Given this list of marker genes Alkbh5 (alkB homolog 5, RNA demethylase), Fto, here is a description of the gene set: electronically inferred by orthology from the curated human pathway This event has been computationally inferred from an event that has been demonstrated in another species.<p>The inference is based on the homology mapping from PANTHER. Briefly, reactions for which all involved PhysicalEntities (in input, output and catalyst) have a mapped orthologue/paralogue (for complexes at least 75% of components must have a mapping) are inferred to the other species. species: Mus musculus Reactome Pathway: Reversal of alkylation damage by DNA dioxygenases part of: DNA Damage Reversal